The following is a description of a gene set: Pathway Definition from KEGG: (SLC16A10,SLC16A2) -> T3 -> (THRB,THRA) == RXR => (MYH6,ATP2A2) studied in species Homo sapiens Human Gene Set: KEGG_MEDICUS_REFERENCE_THYROID_HORMONE_SIGNALING_PATHWAY Thyroid hormone signaling pathway. Pathway ID: N00798. Pathway type: Reference. Pathway class: nt06322 TRH-TSH-TH signaling., and this is the list of marker genes: SLC16A10, THRB, SLC16A2, RXRG, MYH6, THRA, RXRA, RXRB, ATP2A2